Given this list of marker genes CDKL3, SCAPER, TK2, UBE2B, ZNF606-AS1, MFAP1, KHSRP, UTP11, ABLIM3, TASOR, TSSK3, RAD9B, CDIP1, C10orf88B, LACTB2, CCNT1, ZNF14, VRK3, ZNF628, TMEM167B, THAP7, DHX40, NOC3L, XKR9, CENPS-CORT, EBLN3P (endogenous Bornavirus like nucleoprotein 3, pseudogene), SNRPD1, ZNF790, OSCP1, THAP7-AS1, ARFGAP3, EVI5, ALDOA, TMED1, ASAH2B, TMEM167B-DT, GSR, SUGP2, RFX2, CENPS, COPS7A, RIOK2, MEPCE, TASOR2, ARMC6, WDR36, PHF20, FAM24B, ZCCHC7, FANCD2, RHBDD1, DNAJC11, MGA, SPOP, TLCD3B, RPA2, ATL3, ZNF606, ARHGEF1, INTS3, DERL2, DHDDS, ERP29, ZNF473, GCC1, CIDECP1, RFC1, MIS12 (NCBI Gene Id 79003), SEH1L, AMN1, VPS29, DDX50, C19orf38, CKLF, CCDC126, TMEM116, CKLF-CMTM1, here is a description of the gene set: Genes containing one or more binding sites for (PCGF6) in their promoter regions (TSS -1000,+100 bp) as identified by GTRD version 20.06 ChIP-seq harmonization. studied in species Homo sapiens from publication Yevshin I, Sharipov R, Kolmykov S, Kondrakhin Y, Kolpakov F (PMID 30445619) Human Gene Set: PCGF6_TARGET_GENES